The following is a description of a gene set: The formation of a protein tetramer, a macromolecular structure consisting of four noncovalently associated identical or nonidentical subunits. Mouse Gene Set: GOBP_PROTEIN_TETRAMERIZATION species: Mus musculus, and this is the list of marker genes: Oxa1l, Appl2, Tdo2, Stk3, Aldh1a3, Apip, Grin1, Cryz, Osbpl2, Crtc3, Samhd1, Aldoa, Trpa1, Hsd17b8, Trpm4, Tk1, Trpv5, Shmt1, Aqp2, Cpsf7, App, Mip, Trpm1, Ms4a1 (membrane-spanning 4-domains, subfamily A, member 1), Hsd17b10, Me1, Usp16 (NCBI Gene Id 76164), Snca, Sod2, Kcnj2, Golga2, Trpv6, Aqp5, Kcnj12, Ryr3, Trp53, Itpr3, Dnm1, Cutc, Gls, Gnmt, Trp63, B2m, Hprt1, Aldh9a1, Homer1, Pkd2, Pkd1, Trpv1, Kcnd3, Gbp5, Cbr4, Kcnn4, Pkd2l1, Cby1, Trpm2, Thg1l, Evl, Krt1, Rrm2, Hcn1, Mcoln1, Stk4, Trp73, Acacb, Mavs, Trpm6, Fkrp, Itpr1, Krt10, Pkm, Nudt21, Kcnt1, Gria2, Mat1a, Sycp1, Rrm1, Shmt2, Vasp, Aldh1a2, Acaca, Kcnc3, Gria3, Upb1, Farsa (phenylalanyl-tRNA synthetase, alpha subunit), Cpsf6, Col6a1, Snupn, Ssbp1, Acot13, Ryr1, Trpm7, Pex5, Grin2b, Cth, Kcnc1, Crtc2, Aqp4, Farsb, Crtc1